Given this list of marker genes EFNA5, SLC25A18, C1orf74 (NCBI Gene Id 148304), IRF2, BSN, WNT2, ATL2, ATP11B, COPB1, PPA2, MSX2 (NCBI Gene Id 8053), DUSP1, SUSD4, PDGFB, TPX2, SLIT3, ZNF316, MAP3K20, ATPSCKMT, AIDA, C5, NR2C1 (nuclear receptor subfamily 2 group C member 1), CHSY1, PAK6-AS1 (PAK6 antisense RNA 1), DET1, ONECUT2, NUAK2, TMEM35A, RAB6B, SCN1A, SLC35C1, GRID2, ARMC3, POU6F2, DPP10, CD58, THAP12, SEC63, KCNA1, LRPAP1, ATXN7, IQSEC2, VCAN, NR2F1, NAALAD2, XPR1, SOST, TLN2, KDM5B, MCL1, THEMIS (NCBI Gene Id 387357), HMGCS2, PRMT3, NRP1, SEPTIN6 (NCBI Gene Id 23157), LMO4, MOGAT3, SLC4A1, AMT, here is a description of the gene set: from publication Chen Y, Wang X (PMID 31504780) Human Gene Set: MIR1289 studied in species Homo sapiens Genes predicted to be targets of miRBase v22 microRNA hsa-miR-1289 in miRDB v6.0 with MirTarget v4 prediction scores > 80 (high confidence targets).